Given this list of marker genes UBE2I, NUP54, RAN, RANGAP1, AHCTF1, NUP133, NDC1, KPNB1, NUP107, NUP37, SEH1L, NUP98, SEC13, NUP160, NUP43, TNPO1, RCC1, NUP205, NUP85, NUP58, SUMO1, NUP93, NUP188, NUP35, NUP155, POM121, NUP62, here is a description of the gene set: Reactome Pathway: Postmitotic nuclear pore complex (NPC) reformation The NPC is reassembled during late anaphase/telophase when nascent nuclear membranes associate with the chromatin surfaces. Assembly of specific NPC proteins (nucleoporins) into the reforming NPC occurs in a temporally ordered fashion. The GTPase RAN plays a central role in regulating NPC assembly during telophase, as well as earlier events in mitosis, such as mitotic spindle assembly. The active form of RAN (RAN:GTP), which is generated by the chromatin-associated RAN guanine nucleotide exchange factor RCC1, is converted to the inactive form (RAN:GDP) by the cytoplasmically localized RAN GTPase activating protein RANGAP1. During telophase, the elevated RAN:GTP near chromatin releases nucleoporins from complexes with nuclear transport receptors, including KPNB1/KPNA (importin alpha/beta) and TPNO1 (transportin), thereby liberating the nucleoporins for NPC assembly. part of: Nuclear Envelope (NE) Reassembly studied in species Homo sapiens